The following is a description of a gene set: Here we have used a systems biology approach to study innate and adaptive responses to vaccination against influenza in humans during three consecutive influenza seasons. We studied healthy adults vaccinated with trivalent inactivated influenza vaccine (TIV) or live attenuated influenza vaccine (LAIV). TIV induced higher antibody titers and more plasmablasts than LAIV did. In subjects vaccinated with TIV, early molecular signatures correlated with and could be used to accurately predict later antibody titers in two independent trials. Notably, expression of the kinase CaMKIV at day 3 was inversely correlated with later antibody titers. Vaccination of CaMKIV-deficient mice with TIV induced enhanced antigen-specific antibody titers, which demonstrated an unappreciated role for CaMKIV in the regulation of antibody responses. Thus, systems approaches can be used to predict immunogenicity and provide new mechanistic insights about vaccines. Genes down-regulated in B cell 7d vs 0d in young adults (18-50) after exposure to FluMist, time point 7D from publication Nakaya HI, Wrammert J, Lee EK, Racioppi L, Marie-Kunze S, Haining WN, Means AR, Kasturi SP, Khan N, Li GM, McCausland M, Kanchan V, Kokko KE, Li S, Elbein R, Mehta AK, Aderem A, Subbarao K, Ahmed R, Pulendran B (PMID 21743478) Human Gene Set: NAKAYA_B_CELL_FLUMIST_AGE_18_50YO_7DY_DN species: Homo sapiens, and this is the list of marker genes: TSFM, SERPINB1, CD300A, MYCBP, GPAA1, AKAP13, GYPC, PLGLB1, KPNA1, ELF2 (NCBI Gene Id 1998), HPSE, FHL3 (NCBI Gene Id 2275), GNS, PSMG2, UPP1, TIMP1, CLEC7A, TNFAIP3, RASA1, DZIP3, LILRA1, C1QBP, TGFBI, IGHG3, BAZ1A, KLF11, PRKAG2, TTC21B, SENP2, MAP4K5, FCN2, ZNF710, SRGN, TLR7, CENPF, LILRA2, C5orf15, HLA-DRB5, CD44, MARCHF5 (membrane associated ring-CH-type finger 5), H2AC8, NOC3L, IL27RA, API5, SEC23B, SYNJ2, ELF4, SCO2, CD58, ROGDI, STX17, NFE2L1, TFE3 (NCBI Gene Id 8244), SGPL1, PHACTR2, IL6ST, HLA-DRB1, COQ9, RBM19, FOSL2, OAS3, HLA-DRB3, NAMPT, CES1, RHOBTB3, CD84, MASP2, RERE, ICAM1, USP1, COL9A3, CBLL1, CDS2, WARS1, GOSR2, RBPJ, DESI2, RPE, HAAO (NCBI Gene Id 23498), MRPS15, ARL1, SNIP1, CAPNS1, MNT, QKI, AZIN1, CSGALNACT2, RABGGTB, PLCD1, KPNB1, LYL1, KLHL11 (NCBI Gene Id 55175), TACC1, CLIC4, BST2, PLK3, LMNA, HADHA, HPS1, SKAP2, LGALS3, ALOX5, SLC35A1, SLC35F5, AK2, P2RX1, EIF4G1, CSNK1D, SNRNP35, HIPK2, RCN1, NPL, KAT6B, PML, ANAPC5, H1-4, MAP2K7, FARP1, LGALS8, PIN1, PRPF38B, IGHA2, OPA1, SRSF10, SLC24A1, GLB1L, POLR1G, ERCC1, PPARD, DPP4, ADSL, SLC1A4, PIGH, CDK2AP2, IGHM, PRRC1, UTP14A, FGR, LGALS1, RNF115, GPD2, KPNA6, PARP8, BLVRA (biliverdin reductase A), SULT1A3, CALM1, ACOX1, YES1, ATP6V0D1, GLYR1, CELF1, RABGEF1, PI4KA, PPP1CA, IGFBP7, SLC12A7, KCNN3, CD59, UPF1, VPS26C, PSD3, TNPO1, S100A8, ANXA4, PITPNC1 (NCBI Gene Id 731962), KAT6A (lysine acetyltransferase 6A), BCL3, B4GALT1, CTBP2 (C-terminal binding protein 2), ATXN7, FNTB, TOR1AIP1, RAB1A, HDGF, MAPKAP1, CREM, TRAM1, PPP1R9A, ATP5PO, APAF1, MNDA, PSME3, NIBAN1, SNX1, NIPBL, MLX, TPK1, UTP14C, ERAP1, CNOT4 (CCR4-NOT transcription complex subunit 4), PPP3R1, PTPRS, NREP, VAMP3, STAMBP, PSTPIP1, ADNP2, PLEC, BABAM2, PECAM1, PIGC, IGHD, CAMSAP1, APIP, NECAB3, PIK3CB, IFI30, CCDC47, KATNA1, RBM5, VPS11, TM2D1, TFRC, CIZ1, AHCYL1, BRCC3, ACVR1B, BCL2L13, PTEN, ATAD2B, KMT2A, NPHP4, SENP5, SMARCD1, SON, ZNF148, HK2, NCR3, WDR45B, NMD3, SULT1A4, FIS1, LTN1, LYN, ALDH18A1, RDX, REXO2, PCGF3, CYLD, PTPN12, TMEM11, PLGLB2, MDM2, PLXNC1, CD244, YWHAH, EMC1, POLR1C, ATAD2, MAPKAPK2, TSG101, RIGI, ID2B, COX5B, TFAM, NCF2, SYNE1, IL10RB, NUP210, HIGD1B, C8orf44, CLTA, RRN3, GART, LYZ, CACNA2D3, TLE4, LUC7L, KIF2A, GTF2I, ACVR2A, DDX21, WDR41, GTPBP1, DNAJB6, HMGXB4, INPP1, SECISBP2L, ATP6AP2, ZNF532, TFB2M, YLPM1, GAS7, AHNAK, MFAP1, CNIH4, RUFY3, SSRP1, CEBPD, DYRK1A, GBP1, TASL, CD86, PRDX1, MED27, ACOX3, ATP2B4, KYNU, CAPRIN1, UBE2D1, UTP18, CDC37, RNASEH1, IGHA1, CYP1B1, APOBEC3F, MYH10, FHOD1, OAZ2, ADISSP (NCBI Gene Id 54976), ID2, AHR, MBD4, SWAP70 (switching B cell complex subunit SWAP70), EBAG9 (NCBI Gene Id 9166), RNPEPL1, PEBP1 (phosphatidylethanolamine binding protein 1), TRIB3, PHC1 (NCBI Gene Id 283368), RAB4A, EMG1, GK (glycerol kinase), HSPA9 (NCBI Gene Id 91471), USP13, ARIH1, SERINC5, IGHG1 (immunoglobulin heavy constant gamma 1 (G1m marker)), MARS1, ZFYVE26, GLB1, HIP1R, LPCAT3 (lysophosphatidylcholine acyltransferase 3), SCAF11, PHF3, PIK3R1, CRYBB2, MED1, TBL1XR1, APOA2, EIF4EBP2, ECE1, TRAF6, LINC03124, NSUN6 (NOP2/Sun RNA methyltransferase 6), RIN2, SUPT6H, KAT7, LDOC1, BRD3OS, IFNGR1, ZNF292, SMG6, ARG2, EIF4A3, MRC2, FBXO9, PES1, CFAP410, TMEM135, ALCAM, CLMN (calmin), WIPI2, APPL2 (adaptor protein, phosphotyrosine interacting with PH domain and leucine zipper 2), U2AF1, EIF4E2, ATXN2L, SULT1A2, AP4E1, FYN, ATG13, NEO1, CTNNA1, SPTLC2, CMC4, CLU, TAF9B, HLA-DRB4, ZFAND6, CBX6, H1-0, IDH3B, POLR2E, ARL4C, PLAAT4, MAP7D1, NCOA2, TOR3A, ICE1, QSOX1, NID1, FEZ2, DUSP7, KLF8, PSMB2, RIN3, LANCL2, SPAG9, ZNF324, TNFSF13